Given this list of marker genes TENT5A, SNX18, PIAS1, VPS13B, MINAR2, SMARCAL1, KLRG1, RELL1, FAM184A, CSF3R, CD84, AP1G1, IDE, TTC38, ABRAXAS2, KIF16B, NCKAP1 (NCBI Gene Id 9864), NCOA4, NUF2, SH2D1B, CYTL1 (cytokine like 1), PLCL2, LY86, KMT2A, SLC25A24, MDGA2 (NCBI Gene Id 161357), TMED8, DENND6A (NCBI Gene Id 201627), WDR7, CAV1, TTF1 (NCBI Gene Id 7270), CSF1R, COX7B2, RASSF3, GAS2L3, HEPACAM, OPRL1, SPTBN1, COPB1, BTBD10, NRDC, ARHGEF6, SPTY2D1, ERI1, AP1S2, KRT4, CFAP53, IQGAP2, SYTL2, SGO2, CDC14A, TNKS2, BBOX1, CRADD, CLSPN, WNK1, F2R, SUB1, MTURN, GGPS1, IGSF21, SERPINA11, SLC16A4, CCDC136, ABRAXAS1, USP38, SLC4A10, TOP2A, CELF2, NCOA2, PLXNC1, ZNF260, CBX5, KIF11, CROT, TXNDC9, CYP4V2, ARFIP1 (NCBI Gene Id 27236), RHOQ, HERC1, MIA3, EPB41L2, MAPRE1, PLEK, HCFC2, CSMD2, BCL11B, RBMS1 (NCBI Gene Id 5937), UGP2, ANLN, VPS41, ANKRD52, PTPN22, KLF6 (NCBI Gene Id 8025), RPS6KA5, MED7, TAF5, UBLCP1, NCF2, C2orf72, PCDHB1, VASH1, TRAM1, ADGRE1, IRF7, KBTBD7, RIGI (RNA sensor RIG-I), NUDT12, TRIM21, PTMS, SEPTIN10, FAM13B, DNASE1L3, POU2F1, FYN, SGO1, MOB4, NUSAP1, GNPDA2, CNOT6, HMGXB4, DIPK1A, RBL1, TUT1, ZDHHC15, DLGAP5, GNA14, DENND4C, HCK, ABRACL, TMEM98, SCCPDH, SLC22A17, UBE2B, GRIN2A, SNX10, EXTL1, ATP10D, CTBP2, ATL2, BET1, ABTB3, MOB1A, NGLY1, ZNF566, ALOX5AP, CGGBP1, PLEKHH2, TREML4, MARCHF6, HPF1, APAF1, ITGA1, CASP7, CHMP5, TBL1XR1, ESYT2, ASPM, CAMK1G (NCBI Gene Id 89759), RASGRP1, MS4A18, CD200R1L, LGMN, ZYG11B, SEMA5A, ATP8B4, RSPO4, LIPK, ZC2HC1C, RTF1, OLIG1, FAM204A, FRMD3, GABRR2, SSTR2, CTCF, FBXO5, SSR3, CCDC175, ECT2 (NCBI Gene Id 55710), MLLT10, REEP3, MYOZ1, MAPK9, ETFRF1, STARD4, ARHGEF3, CECR2, AP3B1, ITGA6, DBF4, TNKS, AKAP10, NR4A3, GOLT1A, CLEC4A, ISX, CD300A, MS4A7, here is a description of the gene set: Genes down-regulated in comparison of effector CD8 T cells KRLG1 Int vs those with KRLG1 Hi. Using killer cell lectin-like receptor G1 as a marker to distinguish terminal effector cells from memory precursors, we found that despite their diverse cell fates both subsets possessed remarkably similar gene expression profiles and functioned as equally potent killer cells. However, only the memory precursors were capable of making IL-2 thus defining a novel effector cell that was cytotoxic, expressed granzyme B, and produced inflammatory cytokines in addition to IL-2. This effector population then differentiated into long-lived protective memory T cells capable of self-renewal and rapid re-call responses. Mechanistic studies showed that cells that continued to receive antigenic stimulation during the later stages of infection were more likely to become terminal effectors. Importantly, curtailing antigenic stimulation towards the tail-end of the acute infection enhanced the generation of memory cells. These studies support the decreasing potential model of memory differentiation and show that the duration of antigenic stimulation is a critical regulator of memory formation from publication Sarkar S, Kalia V, Haining WN, Konieczny BT, Subramaniam S, Ahmed R (PMID 18316415) Human Gene Set: GSE10239_KLRG1INT_VS_KLRG1HIGH_EFF_CD8_TCELL_DN species: Homo sapiens